The following is a description of a gene set: Mouse Gene Set: GOCC_FILTRATION_DIAPHRAGM studied in species Mus musculus A specialized cell-cell junction found between the cells of the excretory system, which provides a barrier for filtration of blood or hemolymph., and this is the list of marker genes: Nphs2 (NCBI Gene Id 98428), Podxl, Trpc6, Iqgap1, Ppp3ca, Nrxn1, Cd2ap, Nphs1, Magi2, F11r, Kirrel2 (kirre like nephrin family adhesion molecule 2)